Given this list of marker genes OPHN1, PPP2R5D, PUF60, KMT2A, DNAJC13, KDM5C, CNTNAP2, GBA1, GIGYF2, MAOA, GATAD2B, SNCA, EIF4G1, VPS35, ZFX, LRRK2, MED12, SMARCA2 (SWI/SNF related, matrix associated, actin dependent regulator of chromatin, subfamily a, member 2), GNB2, POGZ, here is a description of the gene set: Low frustration tolerance The feeling of frustration can be defined as an emotional reaction that occurs when a desired goal is not achieved. Frustration intolerance is defined as an age-inappropriate response to frustration, characterized by crying or temper tantrums in children, or aggressive or other undesirable behaviors. Human Gene Set: HP_LOW_FRUSTRATION_TOLERANCE species: Homo sapiens